The following is a description of a gene set: Human Gene Set: GOMF_DOUBLE_STRANDED_DNA_EXODEOXYRIBONUCLEASE_ACTIVITY studied in species Homo sapiens Catalysis of the sequential cleavage of mononucleotides from a free 5' or 3' terminus of a double-stranded DNA molecule., and this is the list of marker genes: FEN1, APEX1, TREX1, APEX2, TREX2 (three prime repair exonuclease 2), EXO1, RAD1, RAD9A